The following is a description of a gene set: Any process that modulates the frequency, rate or extent of symbiosis, an interaction between two organisms living together in more or less intimate association. species: Mus musculus Mouse Gene Set: GOBP_REGULATION_OF_BIOLOGICAL_PROCESS_INVOLVED_IN_SYMBIOTIC_INTERACTION, and this is the list of marker genes: Cxcl5, Tmprss2, Trim30c, Trim30d, Trim38, Arg1, Tmprss4, Furin, Bst2, Hs3st5, Bsg, Trim11, Trim30b, Pomc, Exoc2, Cxcl1, Fbln1, Trim5, Bpifa1, Fuca2, Exoc7, Bpifa5, Trim15, Trim12c, Ch25h, Lgals1, Cav1, Ppara, P4hb, Hmgb1, Cd74, Smpd1, Trim12a, Trim30a, Cd4, Nectin2, Ltf, Fmr1, Trim25, F2rl1, Trim62, Itgav